Given this list of marker genes AW551984, Nkx2-5, Mesp1, Itgb1, Wt1, Rbpj, Isl1, Tbx5, Tenm4, Sox17, Tbx18, Bvht, Acvr1, Tbx3, Wnt3a (wingless-type MMTV integration site family, member 3A), here is a description of the gene set: Mouse Gene Set: GOBP_CARDIAC_CELL_FATE_COMMITMENT species: Mus musculus The commitment of cells to specific cardiac cell fates and their capacity to differentiate into cardiac cells. Cardiac cells are cells that comprise the organ which pumps blood through the circulatory system.